The following is a description of a gene set: Mouse Gene Set: MIR_7214_5P Genes predicted to be targets of miRBase v22 microRNA mmu_miR_7214_5p in miRDB v6.0 with MirTarget v4 prediction scores > 80 (high confidence targets). species: Mus musculus from publication Chen Y, Wang X (PMID 31504780), and this is the list of marker genes: Rhoq, Bmi1, Sypl1, Sox6, Cxadr, Mtmr4, Rgs17, Pdzrn4, Dnai4, Zfp462, Plxna2, Rbms3, Phip, Arl6ip6, Tbx4, Keap1, 9330159F19Rik, Ugcg, Fgf10, Mef2a, Thrap3, Dctn4, Mal, B3galt1, Ube2a, Pex12, Myo1h, Bdnf, Rufy2, Erh, Eaf2, Traf3, Gria4, Plrg1, Selenof, Ppp2r3a, Ubp1, Zic2, Slc30a4, Gnaq (NCBI Gene Id 71788), Smad2, Col11a1, Fcgr2b, Srgap1, Bcl2l2, Rcn2, Nup35, Cdh23, Zswim6, Pigm, Cadm2, Pdgfra, Wee2 (WEE1 homolog 2 (S. pombe)), Gimap6, Slc6a4, Serbp1, Rhoj, Pgap1, Tmed8, Sntb1, Zfp704, Hoxb6, Ctdsp2, Diaph2, Papss2, Gna11, Cp, Ppp1r2, Mog, Phc3, Slc30a9, Tnik, Zeb1, Lpar1, Lrrtm2, Dmrt1, Pik3ca, Prdm5, Pus7l, Pfn2, Tyr, Fstl5, Dcbld1, Cd200r3, Thrb, Col15a1, Ctbp2, Hook3, Ntrk2 (neurotrophic tyrosine kinase, receptor, type 2), Csnk1g3, Cul3, Sox2, Marchf5, Cnot11, Trp53inp1 (NCBI Gene Id 72576), Strbp, Zfp503, Slc24a5, Lrrc10, Pkp2, Slc12a2 (NCBI Gene Id 20496), Galnt3 (polypeptide N-acetylgalactosaminyltransferase 3), Fbxo48, Tmem167, Zfp40, Ufl1, Klhl1, Pde1a, Fam120a, Nova2, Adgra2, Kif18a, B4galt6, St6galnac3, Cnot4, Taok3, Polr1f, Chl1, P2ry12, Pml, Sema5a, Ammecr1, Slc5a7 (NCBI Gene Id 63993), Kmt5a, Togaram1, Eml4, Ano3, Slc35a5, Ap1g1, Zzz3, Rbfox1, Acaa1a, Pcdh15, Shank3, Fndc5, Cdhr1, Patj, Osbp2, Purb, Dynlt3, Zfp1008, Pdia6, Atf6, Cacnb4, Ints4, Vsnl1, Zfp729a, Cavin2, Naaladl2, Slc19a3, Enpp1, Itga4, Ppfia2, Uchl5, Faxc, Plekha8, St6galnac1, Trim52, Usp29, Bcl10, Slc10a2, Zmat1, Cd226, Ndst3, Fam20b, Cntd1, Xrcc4, Stx18, Bnc1, Unc80, Gpr82, Atp2a2, R3hcc1l, Ccne2, G3bp1, Iqsec1, Celf2, Plcl1, Chrna5, Haus6 (NCBI Gene Id 76139), Cops2, Megf11, Tmcc3, Cyth3, Atxn1, Matr3, Dcx, Capzb, Zbed4, Sncaip, Gosr2, Prlr, Ntrk3, Slc22a28 (solute carrier family 22, member 28), Pde8b, Rorb, Tbx21, Zfand5, Pdzd8, Micu3, Ntng1, Palld, Gadl1, Dmd, Dmac2l, Cdk6, D1Pas1, Sema3d, Rnase1, Gabra4, Mob4, Ddi2, Sos1, Vipr2 (vasoactive intestinal peptide receptor 2), Sim1, Glt8d1, Gm3604, Lcorl, Ap4s1, Znrf3, Bbs5, Dcun1d4, Fbln7, Syt6, Acvr2a, Ripk2, Plk4, Dmtf1, Trim33, Tcfl5, Isg20l2, Kdm6a (lysine (K)-specific demethylase 6A, NCBI Gene Id 22289), Itm2b, Ncoa2, Sf3b6, Sh3bgrl2, Acbd5, Atp6ap2, Mmp21, Obox6 (NCBI Gene Id 52031), Aknad1, Arfgef3, Ppm1b, Zfp229, Kpnb1, Hook1, Rnf128, Pdzd11, Nus1, Ldb2, Tmem263, Twsg1, Zfp322a, Ythdf1, Bicd1, Speer4a2, Ralgapb, Myo9a, P2rx7, Defb3, Mdm2, Trdn, Unc13c, Pign, Tmem132b, Ccr2, Itprid2, Grm3, Manea, Rsf1, Klf9, Kxd1, Tex12, Ncam2, Stap1, Lrrc18, Ubr3, L3mbtl4, Kctd1, Clip1, Bmp3, Oxr1, Ddx60, Efhd1, Trpc5, Neil3, Kcnv1, Arrdc3, Smc6, Ubxn2b, Klhl12, Vapa, Atg4b, Frmd7, Smg1, Eif2s3x, Cyp2c23, Cdh1, Insr, Gmfb, Tgfb2, Zmym2, Ptchd1, Kcnd3, Kcnab3, Ppfibp2, Cbfa2t3, Trib2, Erbb4, Rora (NCBI Gene Id 319897), Mospd1, Ksr1, Suds3, Yes1, Gabpb2, Ttll7, Magi1, Nf1, Vgll3, Hmox2, Zfp979, Dnaja1, Nudt18, Lhx8, Ppp2r5e, Fut9, Sars1, Slc4a4, Nr2c2, Meox1, Zfp217, Mtmr6, Apc, Clrn1 (NCBI Gene Id 229320), Fmr1 (fragile X messenger ribonucleoprotein 1), Atg12, Nol4, Nrxn2, Msx3, Trim56, Neurod2, Mfsd4a, Fhip1b, Cep15, Kcnk2, Scel, Zfp90, Ssh2, Tbl1x, Enox1, Uck2, Chtop, Hnrnpr, Map1b, Unc5b, Gpr141, Lpp, Zyg11b, Tiparp, Tjp1, Foxk2, Arhgap25, Lgalsl, Msantd2, Hao1, Prkg1, Mill1, Meis1 (Meis homeobox 1), Afg2a, Cux1, Nudt11, Pja1 (praja ring finger ubiquitin ligase 1), Vcpip1, Pawr